Given this list of marker genes GET4, CTBP1, FOXG1, ALMS1, SNX14, GNAI1, SDHB, WASF1, ACTA1, CLDN11, GRIK2, ADCY5, HIVEP2, MEF2C (NCBI Gene Id 4208), CASK, NAT8L, SLC18A2 (solute carrier family 18 member A2), OTUD7A, NEUROD2, ZNF142, LARGE1, POLR3K, CHRND, WDR26, PLP1, EXTL3, TRIO, CTNNB1, MKS1, VPS35L, PCYT2, SLC39A8, ITPR1, PGAP1, INPP5E, VRK1, OPHN1, MBD5, GAA, SON, HK1 (NCBI Gene Id 59333), AP3B2, VPS51, ROBO3, COL3A1, CELF2, GRIN1, SIK3, DAG1, ADGRL1, ESAM, PAFAH1B1, UGDH, AHDC1, MACF1, CHRNB1, GRIN2B, NARS1, NEXMIF, FTH1, KAT6A, CUL3, TUBB3, TAF8, DCPS, TAF4, MDH2, TRIM8 (tripartite motif containing 8), EIF3F, SATB1, TTC5, SLC25A42, NGLY1, GALNT2, MECP2, VAMP1, RBL2, CDK13, DPYSL5, H3-3A, SLC9A7, RAB3GAP2, POLR2A, here is a description of the gene set: Human Gene Set: HP_DELAYED_ABILITY_TO_SIT A failure to achieve the ability to sit at an appropriate developmental stage. Most children sit with support at 6 months of age and sit steadily without support at 9 months of age. Delayed ability to sit studied in species Homo sapiens